Given this list of marker genes Zc2hc1a, Serpinb1a, Bpifa2, Sfmbt2, Kcnq1ot1, Rgs1, Mageh1, Kcnn4, Abcb1a, Xist, Bicd1 (NCBI Gene Id 319962), Tanc1 (tetratricopeptide repeat, ankyrin repeat and coiled-coil containing 1), Rab30, Irs2, B4galt6, Sat1, Jun, Eid2, Plod2, Kif13a (NCBI Gene Id 328239), Smr3a, Zbtb10, Aig1, Bcl11b, Spp1, Rnf43, Dock5, 1810021B22Rik, Nfic, Atxn1 (ataxin 1), Tnfrsf21, Laptm4b, Cystm1, E130311K13Rik, Nrip1, Tmem191, Enah, Klf7, Klf6, Slc30a1, Trim12a, G6pc3, Ckb, Ak7, Rnf125, Map9, Lncpint, Egln3, Ift43, Fam234a, Cers6, Fzd6, Soat1, Ctsl, Myof (NCBI Gene Id 71942), Zswim6, Tsc22d1, Vopp1, Apoe, Rab20, here is a description of the gene set: Multiple myeloma is an incurable plasma cell malignancy for which existing animal models are limited. We have previously shown that the targeted expression of the transgenes c-Myc and Bcl-X(L) in murine plasma cells produces malignancy that displays features of human myeloma, such as localization of tumor cells to the bone marrow and lytic bone lesions. We have isolated and characterized in vitro cultures and adoptive transfers of tumors from Bcl-xl/Myc transgenic mice. Tumors have a plasmablastic morphology and variable expression of CD138, CD45, CD38, and CD19. Spectral karyotyping analysis of metaphase chromosomes from primary tumor cell cultures shows that the Bcl-xl/Myc tumors contain a variety of chromosomal abnormalities, including trisomies, translocations, and deletions. The most frequently aberrant chromosomes are 12 and 16. Three sites for recurring translocations were also identified on chromosomes 4D, 12F, and 16C. Gene expression profiling was used to identify differences in gene expression between tumor cells and normal plasma cells (NPC) and to cluster the tumors into two groups (tumor groups C and D), with distinct gene expression profiles. Four hundred and ninety-five genes were significantly different between both tumor groups and NPCs, whereas genes were uniquely different from NPCs in tumor group C and genes were uniquely different from NPCs in tumor group D. Similar to human myeloma, the cyclin D genes are differentially dysregulated in the mouse tumor groups. These data suggest the Bcl-xl/Myc tumors are similar to a subset of plasmablastic human myelomas and provide insight into the specific genes and pathways underlying the human disease. from publication Boylan KL, Gosse MA, Staggs SE, Janz S, Grindle S, Kansas GS, Van Ness BG (PMID 17483317) Mouse Gene Set: BOYLAN_MULTIPLE_MYELOMA_C_DN species: Mus musculus Genes down-regulated in group C of tumors arising from overexpression of BCL2L1 and MYC in plasma cells.